Given this list of marker genes FSHR, FSTL4, CCNE1, ESPL1, PCGF2, ADAMTS12, TMEM106C, NMUR2, AMIGO2, RACGAP1, CBX6, EFNA4, EDA, CACNB3, MLEC, NDUFS2, MYDGF, MAD2L1 (mitotic arrest deficient 2 like 1), SLC4A11, CCDC3, PML, CCR6, TOP2A, MIS18BP1, SSX2IP, TMEM67, MGME1, SHBG, LCE2B, FIRRM, CXCL13, STIL, LYZL4, PAPSS2, CCDC83, HYKK, PRKD1, CTTNBP2, ETV4, UNC119B (unc-119 lipid binding chaperone B), HPD, POLE, NCAPG2, TXLNB, UBE2M, KYAT3, CCN1, FAM181A, ERICH3, APOLD1, TOMM40, POLK, CCDC184, NELFE, ARPC1B, CLMN, SESTD1, SLC16A14, WBP4, FADS1, SPC24, LHX4 (NCBI Gene Id 89884), NRP2, ALPI, SDF2L1 (NCBI Gene Id 23753), LOXL2, PRKAR2A, MRPL20, NEK2, EXTL2, KBTBD13, KHSRP, HTR2B, DSC2, RBPJL, PIK3R6, A1CF, OIP5, CLSTN3, CXCL17, TONSL, NUP133, PRKCSH, HOXD8, MRPL54, DHCR7, PM20D1 (peptidase M20 domain containing 1), ASF1B, GP6, KHDRBS2 (KH RNA binding domain containing, signal transduction associated 2), LOXL4, KNTC1, DHFR, NSG1, SKA3, FBXO2, MASP2, GSTT2, GPR173, KDELR2 (KDEL endoplasmic reticulum protein retention receptor 2), NTNG1, FADS2, CENPT, PRIM1, VSTM2B, MAOA, ACSF3, E2F8 (E2F transcription factor 8), SHMT2, CACNA1S, TPGS1, CA5A, CEP89, RENBP, PRRT4, LRFN1, F8A1, IFITM2, HS3ST6, TKFC, ANK1, HRAS, PLEKHA2, PAQR5, HEPHL1, NUDT2, KIF22, TKT, FZD6, TMEM183A, TMEM160, KDR, DMPK, PRR27, MAP7D1, TBX21, TIMP3, GINS2, SDS, LITAF, GGN, GMPR2, DNMT1, EME1, TEX26, PPIL1, PAX3, SNRNP27, OLFML2A, SKA2, TMEM74B (transmembrane protein 74B), SLC22A14, SRSF9, CASKIN1, TAFA5, PCYOX1L, KCNC1, FAM78B, DNAJB8, PMVK, SLC38A3, NRIP3, MINDY4, LTK, SNX25, LYPLAL1, CDCA5, RRM1, CTNND1, TFRC, SLAMF9, FBXW8, KLF14, BCL2L14, IFT43, CDC20, SHISAL2B (NCBI Gene Id 100132916), GSTT1, DBI, TSPAN2, ARFIP1, GPA33, SRGAP3, KCNK13 (potassium two pore domain channel subfamily K member 13), SUPT3H, CAMK2A, STARD10, MLC1, NEUROG3, GGT5, PILRB, ARHGAP11A, KIF11, YWHAE, ATF5, KIF24, MLXIPL, MRE11, MAPK3, here is a description of the gene set: Genes down-regulated in comparison of regulatory T cell (Treg) from IL2RB defficient mice versus effector T cells from IL2RB defficient mice. Human Gene Set: GSE14350_TREG_VS_TEFF_IN_IL2RB_KO_DN species: Homo sapiens Interleukin-2 receptor (IL-2R) signaling is essential for T regulatory (Treg) cell development and homeostasis. Here we show that expression of IL-2Rbeta chains that lack tyrosine residues important for the association of the adaptor Shc and the transcription factor STAT5 in IL-2Rbeta-deficient mice resulted in production of a normal proportion of natural Treg cells that suppressed severe autoimmunity related with deficiency in IL-2 or IL-2R. These mutant IL-2Rbeta chains supported suboptimal and transient STAT5 activation that upregulate the transcription factor Foxp3 to normal amounts in natural, but not induced, Treg cells. Using cells T cell obtained from normal C57BL/6 mice and mice harboring Treg cells with impaired IL-2R signaling, gene expression profiling revealed many targets in peripheral natural Treg cells that were IL-2-dependent and a substantial overlap between the Treg cell IL-2-dependent gene program and the Treg cell transcriptional signature. Collectively, these findings demonstrate that a critical, and perhaps minor, subset of IL-2-dependent targets in Treg cells is indexed to a low IL-2R signaling threshold and that a substantial proportion of the Treg cell gene program is regulated by IL-2. CD4 T effector cells also showed many IL-2R-dependent gene and these also overlapped in a distintive manner with the IL-2-dependent genes of Treg cells and the Treg gene signature. from publication Yu A, Zhu L, Altman NH, Malek TR (PMID 19185518)